Given this list of marker genes TYRO3, H2AC12, EMSY, ZCCHC8, PKMYT1, SNRPD1, MCMBP, MYC, HCN3, ONECUT1, DNMT1, NUP62, CLSPN, PAX6, SYNCRIP, KBTBD6, TFAP4, SMC6, RPS6KA5, NFATC2IP, MCM8, MTF2, UGGT1, RPS20, H2BC12, TRMT2A, EFNA5, NELL2, ADAMTS2, KCNS2 (potassium voltage-gated channel modifier subfamily S member 2), PAPOLG, WDR62, RASAL2, KBTBD7 (NCBI Gene Id 84078), ID3, MAZ, NCL, EMC3 (NCBI Gene Id 55831, ER membrane protein complex subunit 3), IER5L, NRK (NCBI Gene Id 203447), ASXL2, PRKDC, USP37, H4C1, RET, MCM4, PPM1D, TMEM108, MSH5, RBBP7, STT3B, ING3, DCK, ATF5, SMAD6, CORT, H2AZ2, ARHGAP11A, GRIA4, RANBP1, LUC7L3 (NCBI Gene Id 51747), GSPT1, TAOK2, SEMA6A, MYH10, RIBC1, ILF3-DT, FANCC, BRME1, ARHGAP6, MCM3, SPINK5, VCAN, ZNF367, PIM1, PRPS2, POLE2, CASP8AP2, DNAJC5G, MAP3K7, ATAD2, SASS6, SMC3, TRA2B, OLFML3, H3C1, SP3, ZBTB25, SYNGR4, ZSWIM9, UBR7, NASP, ILF3, TMPO, TRMT6, GAPDH, FANCD2, E2F7, SEZ6, ACO2, MAPK6, BRMS1L, SLC9A5, ZIM2, APH1A, SPTB, ST20-AS1, KMT5A, TMEM143, LHX5, MDGA1, POLE4, HMGA1, AK2, ZNF644, FIZ1, GINS3, TMEM187, CDK1, DMD, PCLAF, ZNF687, KLF4, HNRNPUL1, IPO7, SRSF1, RTBDN, PHF5A, MAT2A, CDCA7, ATAD5, POLA1, PEG3, POLD3, EIF1AX, PRP4K (pre-mRNA processing factor kinase PRP4K, NCBI Gene Id 8899), SLC9A7 (solute carrier family 9 member A7), GPRC5B, CCNT1, APPL1, STK35, GATA1, CBX3, NIPBL, MXD3, ZNF524, DCTPP1, SLCO3A1, HS6ST3, ALDH6A1, HNRNPD, PODN, STAG1, H2AZ1, TIGAR, TBX6, STMN1, PBRM1, ZBTB4, CAND1, EZH2, CDC5L, FANCG, PCNA, GMNN, GEN1 (GEN1 Holliday junction 5' flap endonuclease), ZNF503, PAN2, RBL1, ZNF362, SLC25A14, PCSK1, E2F8, SUMO1, OTUD7B, YTHDC1, TLE3, STAG2, MCM7, DNAJC9, TRMT13, NABP2 (NCBI Gene Id 79035), SMC1A, HNRNPA2B1, IL4I1, FHOD1, MSH2, FMO4, POU4F1, HIRA, MCM6, EHBP1, LIG1, KIAA0825, JADE1 (NCBI Gene Id 79960), PRPS1, ARID4A, MEPCE, POLR2A (NCBI Gene Id 5430), EIF4A1, SRSF7, JADE2, E2F3, ZNF565, TOPBP1, HOXC10, THAP8, RMI2, HNRNPR, POLR1G, MAPT, MRPL40, CTDSPL2, NOLC1, AP4M1, FKBP5, POLD1, ZCWPW1, SOAT1, YBX2 (Y-box binding protein 2), GABRB3, CDC25A, PHC1, RAVER1, NUFIP2, SUV39H1, E2F1, GON7, EPHB1, PAQR4, HMGXB4, KCNA6, AP1S1, MCM2, RRM2, ACBD6, EED, CNOT9, UNG, CDC6, FBXO5, NPR3, here is a description of the gene set: Human Gene Set: E2F4DP1_01 Genes having at least one occurrence of the motif TTTSGCGC in the regions spanning 4 kb centered on their transcription starting sites. This matches the E2F4, TFDP1 transcription factor binding site V$E2F4DP1_01 (v7.4 TRANSFAC). species: Homo sapiens